The following is a description of a gene set: studied in species Homo sapiens Any process that modulates the frequency or rate of heart contraction. Human Gene Set: GOBP_REGULATION_OF_HEART_RATE, and this is the list of marker genes: KCNE3, SREBF1, KCNE2, ACE, SHOX2, IRX5, HEY2, DSC2, BIN1, CACNA1C, ADA, SCN4B, AVPR1A, PRKACA, ADRB1, GJA5, AKAP9, HCN4 (NCBI Gene Id 10021), KCND3, KCNQ1, OXT, RANGRF, SNTA1, ATP2A2, KCNH6, PTPN1, TMEM161B, CAMK2D, DMD, MIR1-1, TNNI3K, MC3R, POPDC2, MDM2, SLC8A1, HCN1, SCN1B, SRI, NOS1AP, FKBP1B, DRD2, KCNJ2 (potassium inwardly rectifying channel subfamily J member 2), RGS4, MYH6, CACNA2D1, TACR3, KCNJ5, EDN2, GCH1, TNF, SPX, KCNE1, TAC1, HRC, SCN10A, GPD1L, MIR328, PDE4D (NCBI Gene Id 654081, phosphodiesterase 4D), NMU, DSG2, ADM5, ADM, CACNA1D (NCBI Gene Id 776), CTNNA3, NPPA (natriuretic peptide A), EDNRA, PKP2, RYR2, SRC, KCNA5, ADRA1A, EDN1 (endothelin 1), DSP, KCNJ8, RNLS (renalase, FAD dependent amine oxidase), CAV3, GJD3, KCNJ3, SCN3B, CALM1, MIR133A1, CACNB2, SCN5A, NPFF, CASQ2 (NCBI Gene Id 845), EDN3, TPM1, APLN (apelin), EDNRB, KCNE5, CACNA1G, KCNH2, MYH7, JUP, PLN, SLC1A1, SPTBN4, KCNE4, SCN2B, EPAS1, CALM3, MIR26A1, YWHAE, ISL1, AGTR2, CAV1, TRPM4, CALM2, HCN3, BVES, ADM2, ANK2